The following is a description of a gene set: Any process that activates or increases the frequency, rate or extent of the chemical reactions and pathways resulting in the formation of hormones. Mouse Gene Set: GOBP_POSITIVE_REGULATION_OF_HORMONE_BIOSYNTHETIC_PROCESS species: Mus musculus, and this is the list of marker genes: Nr5a2, Bmp6, Hif1a, Arnt, Gh, Por, Wnt4, Igf2, Igf1, Dab2, Lhcgr (NCBI Gene Id 16868), Egr1, Cyp17a1, Igf1r, Ppargc1a (peroxisome proliferative activated receptor, gamma, coactivator 1 alpha)